The following is a description of a gene set: Human Gene Set: GOMF_GLUTATHIONE_PEROXIDASE_ACTIVITY Catalysis of the reaction: 2 glutathione + hydrogen peroxide = oxidized glutathione + 2 H2O. studied in species Homo sapiens, and this is the list of marker genes: GSTP1, ALOX5AP (arachidonate 5-lipoxygenase activating protein), GPX3, GPX6, GPX4, LTC4S, GSTA1, CP, CLIC2, GPX2, PRDX6, GSTK1, GPX5 (glutathione peroxidase 5), MGST3, GSTM2, MGST1, MGST2, GSTT1, GPX7, GPX1, GPX8, GSTZ1, PTGES